The following is a description of a gene set: studied in species Mus musculus Mouse Gene Set: GOBP_S_ADENOSYLMETHIONINE_METABOLIC_PROCESS The chemical reactions and pathways involving S-adenosylmethionine, S-(5'-adenosyl)-L-methionine, an important intermediate in one-carbon metabolism., and this is the list of marker genes: Hnmt, Pemt, Amd2, Ahcyl1, Ahcy, Mat2a, Gamt (NCBI Gene Id 14431), Mat2b, Gnmt, Ahcyl2, Amd1, Bhmt2, Pcmt1, Mtrr, Mat1a, Mettl16